The following is a description of a gene set: Mouse Gene Set: TERAMOTO_OPN_TARGETS_CLUSTER_4 Activated forms of Ras family members are prevalent in many cancers where Ras mutants transduce signals essential for transformation, angiogenesis, invasion and metastasis. As a cancer progression model, we used NIH3T3 cells to explore the mechanism of Ras-induced tumorigenesis. Ras family mutants H-RasV12 and Rit79L strongly induced foci formation, while Rho family mutants RhoA-QL, Rac1-QL and Cdc42-QL were less effective. A comparison of downstream transcriptional targets of Ras and Rho family members using a 26 383 element cDNA microarray revealed that the osteopontin (OPN) gene exhibited the best correlation between magnitude of gene expression change and level of foci formation (r=0.96, P<0.001). In association with H-RasV12- and Rit79L-mediated transformation, foci secreted OPN protein and upregulated the OPN receptor CD44, suggesting the novel initiation of an aberrant OPN-CD44-Rac autocrine pathway. In support of this were the following observations. First, RGD-deficient OPN protein-binding activity was present in H-RasV12-transformed cells but not in control cells, and binding activity was inhibited by the CD44 blocking antibody. Second, foci formation, cell invasion and Rac activity were induced by H-RasV12 and inhibited by the CD44 blocking antibody. Third, foci formation by H-RasV12 was substantially reduced by a short interfering RNA (siRNA) specifically targeting OPN expression for knockdown. Fourth, H-RasV12-mediated transformation was not blocked by the GRGDS peptide, suggesting that OPN effects were not mediated by the integrins. Lastly, OPN knockdown affected the downstream expression of 160 '2nd tier' genes, and at least a subset of these genes appears to be involved in transformation. Indeed, four genes were selected for knockdown, each resulting in a disruption of foci formation and/or invasion. These results underscore the role of aberrant autocrine signaling and transcriptional networking during tumorigenesis. from publication Teramoto H, Castellone MD, Malek RL, Letwin N, Frank B, Gutkind JS, Lee NH (PMID 15516973) Cluster 4: genes whose up-regulation peaked 4 days after knockdown of OPN by RNAi in the NIH3T3 cells (fibroblasts) transformed by activated HRAS. species: Mus musculus, and this is the list of marker genes: Ttc39b, Atic, Col3a1 (NCBI Gene Id 98713), Sppl2b, Hint3, Dgcr6, Sema6c, Pmepa1, Fabp1, Ift70b, S100a4, Chek1, Lrpap1, Ldha, Sugt1